Given this list of marker genes TCEAL6, ADPRH, R3HDM2, SHISA7, TMSB15B, MAX, TCEAL3, ABHD6, ZFAND2B, HES7, RNF38, GAS1, NPPC, CXorf58, UBASH3B, BEST4, TERF2, ATP1A1, SLC25A53, SSPN, CENPE, GCA, RIMS2, LBR, TAGLN3, here is a description of the gene set: from publication Chen Y, Wang X (PMID 31504780) species: Homo sapiens Human Gene Set: MIR6753_5P Genes predicted to be targets of miRBase v22 microRNA hsa-miR-6753-5p in miRDB v6.0 with MirTarget v4 prediction scores > 80 (high confidence targets).